Given this list of marker genes CYBB, CAMP, DEFA4, MPO, ELANE, MMP8, BPI, CTSG, AZU1, LCN2, DEFA1, here is a description of the gene set: Interferons (IFNs) are cytokines that possess potent anti-viral and immunoregulatory activities. In contrast, their potential role(s) in anti-bacterial defense and neutrophil activation mechanisms is less well explored. By comparing gene expression patterns between immature and mature human neutrophils, we obtained evidence that intracellular proteases and other anti-bacterial proteins are produced at earlier stages of maturation, whereas the genes for receptors and signaling molecules required for the release of these effector molecules are preferentially induced during terminal differentiation. For instance, mature neutrophils strongly expressed genes that increase their responses to type I and type II IFNs. Interestingly, granulocyte/macrophage colony-stimulating factor was identified as a repressor of IFN signaling components and consequently of IFN-responsive genes. Both IFN-alpha and IFN-gamma induced strong tyrosine phosphorylation of STAT1 in mature but not in immature neutrophils. Functional in vitro studies suggested that IFNs act as priming factors on mature neutrophils, allowing the formation of extracellular traps upon subsequent stimulation with complement factor 5a (C5a). In contrast, both IFN-alpha and IFN-gamma had only little capacity to prime immature cells in this system. Moreover, both IFNs did not have significant anti-proliferative effects on immature neutrophils. These data contribute to our understanding regarding changes of gene expression during neutrophil differentiation and IFN-mediated anti-bacterial defense mechanisms. from publication Martinelli S, Urosevic M, Daryadel A, Oberholzer PA, Baumann C, Fey MF, Dummer R, Simon HU, Yousefi S (PMID 15302890) species: Homo sapiens Human Gene Set: MARTINELLI_IMMATURE_NEUTROPHIL_UP Neutrophil-specific genes up-regulated in comparison of immature with mature neutrophils.